The following is a description of a gene set: studied in species Mus musculus Mouse Gene Set: REACTOME_SODIUM_COUPLED_PHOSPHATE_COTRANSPORTERS Sodium-coupled phosphate cotransporters, and this is the list of marker genes: Slc34a3, Slc34a1, Slc34a2 (NCBI Gene Id 52185), Slc20a2, Slc20a1